Given this list of marker genes Junb, Klf2, Fos, Jun, Emb, here is a description of the gene set: studied in species Mus musculus from publication Cui A, Huang T, Li S, Ma A, Pérez JL, Sander C, Keskin DB, Wu CJ, Fraenkel E, Hacohen N (PMID 38057668) Cytokines mediate cell-cell communication in the immune system and represent important therapeutic targets. A myriad of studies have highlighted their central role in immune function, yet we lack a global view of the cellular responses of each immune cell type to each cytokine. To address this gap, the authors created the Immune Dictionary, a compendium of single-cell transcriptomic profiles of more than 17 immune cell types in response to each of 86 cytokines (>1,400 cytokine-cell type combinations) in mouse lymph nodes in vivo. A cytokine-centric view of the dictionary revealed that most cytokines induce highly cell-type-specific responses. For example, the inflammatory cytokine interleukin-1β induces distinct gene programmes in almost every cell type. A cell-type-centric view of the dictionary identified more than 66 cytokine-driven cellular polarization states across immune cell types, including previously uncharacterized states such as an interleukin-18-induced polyfunctional natural killer cell state. Genes negatively differentially expressed in cell type: NK cell upon treatment with cytokine: FLT3L in mouse lymph nodes in vivo. Mouse Gene Set: CUI_NK_CELL_FLT3L_RESPONSE_DN